Given this list of marker genes LEPR, DAZ3, XPA, HDAC8, CHRM3, TOGARAM1, TEX14, PHF8, LHX4, MCM8, MAP3K1, SIM1, CCDC28B, DKC1, XRCC2, CCDC34, CFTR, ZPR1, ERCC3, DAZ2, PDHA2, ARX, DNHD1 (NCBI Gene Id 387750), BBS9, DUSP6, CEP19, IFT74, SRY, BBS1, WT1, FGFR1, BBS10, SCLT1, CUL7 (NCBI Gene Id 9820), NSMF (NCBI Gene Id 349336), RNF113A, FGF8 (fibroblast growth factor 8), KISS1, CATIP, TERB1, FMR1, ALMS1, DCC, RAB18, SNRPN, SOHLH1, SEMA3A, RPL10L, KLHL10, BBS12, DCAF17, RLIM, POU1F1, MKS1, CDKN1C, NANOS1, ZMYND15, OTX2, NAA10, DNAH10, NR0B1, PNLDC1, PQBP1 (polyglutamine binding protein 1), TTC8, PHGDH, SATB2, WDPCP (WD repeat containing planar cell polarity effector), TYMS, BBIP1, LZTFL1, HESX1, TAC3, TAF4B, HSD3B2, GNRHR, FOXA2, SHOC1, LHCGR, TRIM32, DDX3Y, CUL4B, WWOX, WDR11, NDNF, SLC29A3, GLI2, ARL6, RBMY1A1, FANCM, NR5A1, DMXL2, SCAPER, ZFPM2, FBN1, DAZ1, RNF212, FLRT3, DDB2, DHX37, BBS2, GNRH1, IFT172, KISS1R, CYP11A1, BRCC3, OCA2, CTDP1, TSPY1, STAG3, NHLH2, MKKS, ERCC2, BBS5, ERCC5, GLI3, LEP, FEZF1, CEP112, ATRX, THOC2, B4GAT1, CHD7, HS6ST1, CCDC141, ERCC4, CYB5A, NPHP1, PHF6, FGF17, TBC1D20, SDCCAG8, IFT27, BBS7, AXL, GBA2, PROK2, CYP11B1 (NCBI Gene Id 1584), TEX15, FBXO43, XPC, SPAG17, FAM111A, PMM2, RPL10, SOX9, DNAJC19, POLA1, TDRD9, SAMD9, BBS4 (NCBI Gene Id 585), PROP1, TACR3 (tachykinin receptor 3), CEP290, MSH5, USP9Y, CYP17A1, MAP3K7, CFAP418, FSHB, RSPO1, KDM5C, ANOS1, KCNJ6, MBTPS2, TCTN3, NDN, PROKR2, DAZ4, MOV10L1 (NCBI Gene Id 54456), TEX11, SYCP3, SLC39A4, SOX10, SEMA3E, SRA1, IL17RD, HSPG2, CT55, SOX3, GATA4 (NCBI Gene Id 2626), VAMP7, MAGEL2, MEIOB, SPRY4, OGT, TERB2, SYCE1, here is a description of the gene set: Decreased testicular size Human Gene Set: HP_DECREASED_TESTICULAR_SIZE Reduced volume of the testicle (the male gonad). species: Homo sapiens